Given this list of marker genes CNOT1, NDC80, FANCI, MSH6, RFC4, PTGES3, SLBP, SNRPD1, RBMX, HNRNPA2B1, MCM3, MSH2, NUP153, SNRPE, USP1, SRSF1, RTRAF, SUPT16H, CBX3, KNTC1, TCP1, ILF2, CCT5, SERBP1, DKC1, HNRNPA3P1, SNRPD3, H2AZ1, MRPL42, SSRP1, LRPPRC, MLH1, NUP107, SMC3, CCT2, NCL, PA2G4, TCERG1, U2SURP, RBBP4, EIF2S1, KARS1, here is a description of the gene set: Neighborhood of MLH1 mutL homolog 1, colon cancer, nonpolyposis type 2 (E. coli) in the GNF2 expression compendium studied in species Homo sapiens Human Gene Set: GNF2_MLH1 Neighborhood of MLH1